The following is a description of a gene set: Axonal degeneration/regeneration Human Gene Set: HP_AXONAL_DEGENERATION_REGENERATION A pattern of simultaneous degeneration and regeneration of axons (see comment). studied in species Homo sapiens, and this is the list of marker genes: LMNA, MFN2, MPZ, KIF1B (kinesin family member 1B), LRSAM1, SLC12A6, GDAP1, RAB7A, GBF1